Given this list of marker genes SAR1B, SAR1A, SEC16A, MAPK15, PREB, here is a description of the gene set: studied in species Homo sapiens Human Gene Set: GOBP_REGULATION_OF_COPII_VESICLE_COATING Any process that modulates the rate, frequency, or extent of the addition of COPII proteins and adaptor proteins to ER membranes during the formation of transport vesicles, forming a vesicle coat.